The following is a description of a gene set: species: Homo sapiens Human Gene Set: GOBP_PURINE_NUCLEOSIDE_MONOPHOSPHATE_BIOSYNTHETIC_PROCESS The chemical reactions and pathways resulting in the formation of purine nucleoside monophosphate, a compound consisting of a purine base linked to a ribose or deoxyribose sugar esterified with phosphate on the sugar., and this is the list of marker genes: PPAT, DCK, PAICS, ADSL, ADA, ADK, ATIC, ADSS1, NUDT2, AMPD2, GMPS (NCBI Gene Id 8833), HPRT1, IMPDH2, APRT, AMPD1, IMPDH1, ADSS2, GART, PFAS, AMPD3, DGUOK